Given this list of marker genes Hrh4, Hrh2, Hrh3, Hrh1, here is a description of the gene set: This event has been computationally inferred from an event that has been demonstrated in another species.<p>The inference is based on the homology mapping from PANTHER. Briefly, reactions for which all involved PhysicalEntities (in input, output and catalyst) have a mapped orthologue/paralogue (for complexes at least 75% of components must have a mapping) are inferred to the other species. electronically inferred by orthology from the curated human pathway part of: Amine ligand-binding receptors Reactome Pathway: Histamine receptors studied in species Mus musculus